The following is a description of a gene set: Alkalosis due to excess loss of carbon dioxide from the body. Human Gene Set: HP_RESPIRATORY_ALKALOSIS species: Homo sapiens Respiratory alkalosis, and this is the list of marker genes: OTC, ASS1, CA5A, ASL, CPS1 (NCBI Gene Id 1373), SLC25A15